Given this list of marker genes CCDC181, NEUROD1, FREM1, RAB30, TMPRSS3, FNBP1, RALYL, CA8, NDRG4, NRXN1, CLIP3, SMOC1, RHBDL1, MAPRE3, RASA4, NRG1, PCSK2, PSD, GALNT13, EGLN3, PGAM2 (NCBI Gene Id 5224), DRAIC, DACH1, KCNT2, PTPRN2, CPEB3, EFHD2, ASNS, DPYSL3, SRGAP1, DACH2, SOX21, BAALC, RGS17, KRT7 (NCBI Gene Id 3855), FSTL5, ADCY1, MARK1, ASCL2, NOL4, KCNIP3, INHBB, TCEAL5, ARFGEF3, ASCL1, DLL3, TACC2, CHRD, PRUNE2, NCAM1, ADCY2, SLC29A4, SCN3A, LMBRD2, RASD1, COL22A1, RIC3, COMTD1, SCG3, ELAVL4, LINC01315, DDC, GABRB3, ANKH, DUSP26, SPTBN2, AMIGO2, SYT1, NLRP1, SOBP, VGF, LINC00261, WIPI1, ADGRG1, SCNN1A, FBXW7, GNB5, MAP6, APLP1, ASB13, ESPN, RASSF6, CALCA, KCNH2, TUBB3, CHGA, CRMP1 (collapsin response mediator protein 1), DENND4A, SYT13, LRATD1, A4GALT, NAALADL1, SCGN, GPC6 (NCBI Gene Id 10082), KCNMA1, DNER, MAP2, MAP1B, SLITRK6, MAPK8IP1, TRIM46, CBFA2T3, RGS4, KLK12, ABCA5, TCEAL2, USP20, CHN2, PPP2R5B, ELOVL7, STMN2, RIMKLA (NCBI Gene Id 284716), MGAT4C, KCNA4, CCDC28B, CASZ1, CXXC4, RAB3B, RAB26, MTMR7, PCLO, SLC6A8, ATL1, PDZRN3, MCF2L, RAPGEF4, REXO1, NXPH4 (neurexophilin 4), CADM2, KCNH6, GDAP1, TNFRSF21, SYP, RAB6B, MEG3, TPBG, PKIB, RTN1, ST18, PCDH17, SERP2, INPP1, SMPD3, NEURL1B, TBX1, ANK2, INSM1 (NCBI Gene Id 8196), GAB2, SPECC1, CHGB, ESPL1 (extra spindle pole bodies like 1, separase), CLDN5, TBC1D24, SH3BP4, MFSD6, NCALD, KIF1A, MS4A8, TMEM176B, SEZ6L2, PNPLA7, KCND3, ATP2A3, SLCO3A1, DPP10, GPM6A, DNAJC12, ROBO1, RINL, LHFPL6, DOP1B, CDH2, IZUMO4, NBEA, CAMK2B, SNAP25, RETREG1, TMEM184A, MAOB, SLC16A11, FGF14, TRMT9B, NAAA, QPCT, SLIT1, NRCAM, KCNH3, RIMS2, EPB41L4A, MIR200CHG, OTULINL, SST, SLC18A1, TMEM51, SCG5, RGS7 (NCBI Gene Id 6000), STMN3, NEGR1, KLK11, RIMBP2, KCNJ6, SLC36A4, CPLX2, NEURL1, PPP1R1A, IQSEC1, CELF3, SYT4, DUSP10, ADAM28, TOX3, SMOC2, DGKZ, MIAT, NR0B2, BTBD17, KIF19, RUNX1T1, GCNT1, GCH1, TCERG1L, CEP126, ST8SIA3, SYT11 (NCBI Gene Id 92303), PTPRN, SMIM32, PHGR1, GRIA2, DMPK, RUNDC3A, TMOD2, RASA4B (NCBI Gene Id 100271927), CACNA2D1, SCG2, TAMALIN (trafficking regulator and scaffold protein tamalin), RPRM, GNG4, FAM13C, THSD4 (thrombospondin type 1 domain containing 4), SMIM22, PROX1, CFC1 (cryptic, EGF-CFC family member 1), VWA5B2, TTC39A, INA, OPTN, CACNA1A, CFC1B, PLPPR2, BCL2, TIMP1, RGS11, RCOR2, PLCL1, CACNB2, CDKN2D, NDUFA4L2, CADPS, SRRM4, TMEM176A, ERC2, TTLL7, WSB2 (NCBI Gene Id 55884), BIK, ZMAT3, ELAPOR1, CACNA1H, NAV1, NEBL, GRP, HEPACAM2, USP41P, MISP3, JAKMIP2, TMEM178A, PLCB4, TIGAR, DST, CNIH2, BAIAP3, JAM3, SLC35D3, STX1A, RAP1GAP2, DLL4, NPTX1, HOXB5, AKT3, TOX, TMEM181, DCX, SYT7, CAMK1D, LFNG, HES6, GFRA3, CFAP65, NPDC1, SYT5, AP3B2, SIX1, PDGFD, TAGLN3, BMERB1, here is a description of the gene set: species: Homo sapiens Pulmonary NE precursor from publication He P, Lim K, Sun D, Pett JP, Jeng Q, Polanski K, Dong Z, Bolt L, Richardson L, Mamanova L, Dabrowska M, Wilbrey-Clark A, Madissoon E, Tuong ZK, Dann E, Suo C, Goh I, Yoshida M, Nikolić MZ, Janes SM, He X, Barker RA, Teichmann SA, Marioni JC, Meyer KB, Rawlins EL (PMID 36493756) Human Gene Set: HE_LIM_SUN_FETAL_LUNG_C1_PULMONARY_NE_PRECURSOR_CELL